The following is a description of a gene set: studied in species Homo sapiens Subpopulations of human fetal thymocyte and circulating naïve T cells were obtained through FACS sorting, including CD3-CD4+CD8- intrathymic T progenitor cells (ITTP), CD3intCD4+CD8+ \double positive\ thymocytes (DP), CD3highCD4+CD8- \single positive\ thymocytes (SP4), CD3+CD4+CD8-CD45RA+CD62L+ naive T cells from cord blood (CB4+), and CD3+CD4+CD8-CD45RA+CD62L+ naive T cells from adult blood (AB4+). Genes up-regulated in comparison of CD4 CD8 thymocytes versus naive CD4 T cells from adult blood. Human Gene Set: GSE1460_DP_THYMOCYTE_VS_NAIVE_CD4_TCELL_ADULT_BLOOD_UP from publication Lee MS, Hanspers K, Barker CS, Korn AP, McCune JM (PMID 15210650), and this is the list of marker genes: FSTL1, SRSF3, CHRNA3, GGH, DPPA4, MYL6B, E2F8 (NCBI Gene Id 79733), JAKMIP2, CDC20, EFCAB11, JADE3, CBX5, TMEM231, ATP5F1C, FBXL12, DCP2, FANCI, CENPE, JAM3, GMNN, KPNB1, TBC1D1, PPM1A, NCBP1, PPIA, GAB2, MAGED1, UBA1, IVD, PHLPP1, SND1, PSMB6 (NCBI Gene Id 95505), UGGT1, HMGB3, H2AC8, CDK2AP2, OR7E47P, CD93, SAP30, SHCBP1, HDAC2 (histone deacetylase 2), ATP6V1A, FIRRM (FIGNL1 interacting regulator of recombination and mitosis), EZR, SIVA1, ARHGAP19, FAT1, SMC2, CAPRIN1, UBA5, GFI1, TSPYL5, DBI, ATP1B3, PLSCR1, GORASP1, FABP5, HNRNPAB, MCTS1, SPRED2, UBB, EIF4A3, TIMP2, DSCC1, MCM7, TFDP1, STRAP, SLC25A1, E2F5, PSMA5, CSNK2A1, KIF18B, FERRY3, RPA3, PUDP, COL6A3, KCTD9, MACIR, FXYD2, IDH3A, PIMREG, ARMCX1, SALL2, PPP2CA, MED12, ICMT, RIC8B, ARHGEF7, ENY2, GMEB1, RPL39L, UBE2C, TMEM164 (transmembrane protein 164), LMNB1, EGR3, SPC25, PSMD4, HSPH1, SREK1, CEP97, COPB2, RMI1, TSHR, PSMA6, H3C10, SLAMF1, LDAH (NCBI Gene Id 60526), RAN, PLCH1, AGBL3, MKLN1, AP3S2, CSTPP1, PCCB, KIF15, RFX5, C3orf52, FEZ2, GSK3B, POLR2C, FARP1, EGR1, PDLIM1, CD200, ASRGL1, MIS18A, FADD, GUCY1B1, CHCHD3, PEX5, CD3G, ST3GAL5, BRCA1, SPAG5, SORD, EFNB2, H2BC4, NUP214, MARCKSL1, IGF2BP3, PTP4A2, MLLT11, MYB, ZNF207, UBE2J1, NUP155, ACOT7, TFPI (NCBI Gene Id 7035), STAG3, ACOX3, USP11, PEF1 (NCBI Gene Id 553115), ATP5PF, FECH, CLGN, KIF4A, PTPRCAP, STIL, ECHDC1, SLC25A14, PPP1CA, PSMD9, POLA2, MYH10 (myosin heavy chain 10), FOXM1, PLPP3, HS2ST1, DNMBP, XRCC5, ZNF280D, GBE1, SEC13, ACTR1A, CDK19, SLA, EP300, KCTD5, PTPRK, ERI2, CENPU, TNFRSF21, CDC45 (cell division cycle 45), LDLRAD4, TSPAN9, LRRC1, LSM4, CD38, TRBC1, TAPBPL, ARHGAP32, FAIM, NUP93, BTG3, EXOG, DSG2, AVEN, H4C8, TP53BP1, FDPS, IFT81